Given this list of marker genes APOBEC3F, APOBEC3H, APOBEC3C, APOBEC3A, APOBEC3D, APOBEC3B, here is a description of the gene set: Human Gene Set: GOBP_CLEARANCE_OF_FOREIGN_INTRACELLULAR_NUCLEIC_ACIDS A defense process that protects an organism from DNA or RNA from an invading organism. species: Homo sapiens